Given this list of marker genes Lima1, Neurod1, Ppp3ca (NCBI Gene Id 99901), Prss2, Npc1l1, Negr1, Ireb2, Nmu, Lrcol1, Hip1r, Kcnq1, Pawr, Slc26a7, Cd36 (NCBI Gene Id 12491), Pnlip, Clps, Lipa, Ugcg, Oxt, Muc2, Pgc, Cldn2, Tac4, Slc22a21 (solute carrier family 22 (organic cation transporter), member 21), Ptger3, Cck, Epb41, Hamp2, Inava, Aqp1, Stk39, Arx, Ldlr (NCBI Gene Id 16835), Fgf10, F11r, Tlr4, Slc26a6, Cyp7b1, Madd, Muc4, Abcg5, Isx, Ghsr, Cyp8b1, Crh, Kcnma1 (potassium large conductance calcium-activated channel, subfamily M, alpha member 1, NCBI Gene Id 70528), Slc5a1, Abcb1a, Trpc1, Wnk1, Nod2, Ghrl, Pls1, Heph, Ezr, Chrm1, Chrm5, Mdk, Zfp830, Kcnn4, Cckar, Sox9, Cel, Crhr2, Copa, Tff1, Cckbr, Ctrb1, Abcg2, Pbld1, Gpr39, Tff3, Npsr1, Ucn2, Muc13, Lep, Tymp (NCBI Gene Id 72962), Chrm3, Tff2, Clpsl2, Tlr9, Il10ra (NCBI Gene Id 16154), Hamp, Lpcat3, Vdr, Tifab, Apoa4, Slc9a4, Abcg8, Mmp13, Apoa1, Vil1, Pbld2, Enpp7, Vsig1 (V-set and immunoglobulin domain containing 1), Slco1a5, Comt, Dao, Mogat2, Gcnt3, Aco1, Asah2, Snx10, Wnk4 (NCBI Gene Id 69847), Rbp4, Slc22a5, Dgat1, Scarb1, Fabp1, Npr3, Cldn15, Slc4a9, Neurog1 (neurogenin 1), Cyp39a1, Akr1d1, Aqp5, Il17a, Htr4, Strap, Nkx2-3, Prap1, Nr1h3 (nuclear receptor subfamily 1, group H, member 3), Npc1, Oprk1, Vamp8, Nppc, Apoa2, Tjp2, Cracd, Sct, Fabp2, Wnk3, Hrh2, Nr1h2, Ucn3 (NCBI Gene Id 83428), Npr2, Acat2, here is a description of the gene set: The whole of the physical, chemical, and biochemical processes carried out by multicellular organisms to break down ingested nutrients into components that may be easily absorbed and directed into metabolism. studied in species Mus musculus Mouse Gene Set: GOBP_DIGESTION